Given this list of marker genes BMP2, INPPL1, ATXN1, BMP5, IGFBP3, MYORG, ZFAND2B, TRIM72, PHIP, GHSR, NKX3-1, MIR1-1, IGFBP1, GHRH, CDH3, IGFBP2, MIR29C, IGF1, IGFBP5, GH1, IGFBP4, AR, GHRHR, IGFBP6, CILP, WNT1, here is a description of the gene set: Any process that modulates the frequency, rate or extent of insulin-like growth factor receptor signaling. studied in species Homo sapiens Human Gene Set: GOBP_REGULATION_OF_INSULIN_LIKE_GROWTH_FACTOR_RECEPTOR_SIGNALING_PATHWAY